The following is a description of a gene set: Human Gene Set: GOBP_PROTEIN_DEACYLATION The removal of an acyl group, any group or radical of the form RCO- where R is an organic group, from a protein amino acid. species: Homo sapiens, and this is the list of marker genes: BRMS1, LYPLA1, BEX4, HDAC1, SIRT2 (sirtuin 2), LYPLA2, PRKAA2, SIRT4, SIRT5, FRY, PPT1, HDAC7, TPPP, SIRT1, SIRT7, NOTUM, SIRT6, MAPT, NNMT, ABHD17C, HDAC6 (histone deacetylase 6), ABHD17B, CCAR2, IFNG, SIRT3, PRKAA1, HDAC9, FLNA, ABHD17A, HDAC3, ABHD10, HDAC4 (histone deacetylase 4), EP300